Given this list of marker genes PTCRA, MIRLET7B, IDO1, ITPKB, GAS6, FADD, ST3GAL1, KITLG, NOC2L, SLC46A2, CCR7, RAG1, STAT5A, GPAM, ORMDL3, HCLS1, PRKCQ, HSH2D, TSC22D3, LILRB1, IRS2, IL7R, BCL2, JAK3, BMP4, SLC39A10, CCR5, BCL11B, CD74, MIR17HG, FCER1G (Fc epsilon receptor Ig), PIP, CXCL12 (C-X-C motif chemokine ligand 12), AXL, ARG2, KIFAP3, ADA, BCL2L1, DOCK8, NOD2, BCL6, PDCD1, CCL21, MIF, SELENOS, IL2, EFNA1, IRF7, GHSR, AURKB, FOXP1, RORC, BCL10, CD27, BCL3, CCL19, HIF1A, CCL5, MERTK, here is a description of the gene set: studied in species Homo sapiens Human Gene Set: GOBP_NEGATIVE_REGULATION_OF_LEUKOCYTE_APOPTOTIC_PROCESS Any process that stops, prevents, or reduces the frequency, rate or extent of leukocyte apoptotic process.